The following is a description of a gene set: species: Homo sapiens The directed movement of organelles or molecules along microtubules from the cell body toward the cell periphery in nerve cell axons. Human Gene Set: GOBP_ANTEROGRADE_AXONAL_TRANSPORT, and this is the list of marker genes: KIF1C, AGTPBP1, KIF1B, KIF5A, BLOC1S5, AP3B2 (NCBI Gene Id 8120), AP3M1, HAP1, MAPK8IP3, DTNBP1, BLOC1S1, AP3B1, TRIM46, BLOC1S4, KIF1A, AP3S2, AP3M2, NETO1, MAP2, KIF3B (kinesin family member 3B), KIF5C, RAB21, SPAST (spastin), SPG7 (SPG7 matrix AAA peptidase subunit, paraplegin), BLOC1S2, MGARP, AGBL4, ARL8A, KIF21A, RAB27B, SYBU, SNAPIN, MAP1A, BLOC1S6, FEZ1, HSPB1, NEFL, BLOC1S3, AP3D1, KIF4A, BORCS5, AP3S1, DLG2, ARL8B (NCBI Gene Id 55207), KIF5B (NCBI Gene Id 3830), KIF3A, SOD1